The following is a description of a gene set: PURPOSE: To improve the clinical management of human hepatocellular carcinoma (HCC) by accurate identification, at diagnosis, of patients at risk of recurrence after primary treatment for HCC. EXPERIMENTAL DESIGN: Two clinicopathologic variables available at diagnosis, vascular invasion and cirrhosis, together with molecular profiling using Affymetrix human HG-U133A and HG-U133B oligonucleotide probe arrays, were used to identify recurrent HCC disease. RESULTS: HCC patients presented clinically at diagnosis with vascular invasion and cirrhosis showed a high rate (78-83%) of developing recurrent disease within 6 to 35 months. In comparison, most of the HCC patients (80-100%) without vascular invasion and cirrhosis remained disease-free. However, the risk of recurrent disease for HCC patients with either vascular invasion or cirrhosis could not be accurately ascertained. Using a pool of 23 HCC patients with either vascular invasion or cirrhosis as training set, a 57-gene signature was derived and could predict recurrent disease at diagnosis, with 84% (sensitivity 86%, specificity 82%) accuracy, for a totally independent test set of 25 HCC patients with either vascular invasion or cirrhosis. On further analysis, the disease-free rate was significantly different between patients that were predicted to recur or not to recur in the test group (P = 0.002). CONCLUSION: We have presented data to show that by incorporating the status of vascular invasion and cirrhosis available at diagnosis for patients with HCC after partial curative hepatectomy and a novel 57-member gene signature, we could accurately stratify HCC patients with different risks of recurrence. Genes down-regulated in samples from patients with recurrent hepatocellular carcinoma (HCC). from publication Wang SM, Ooi LL, Hui KM (PMID 17975138) Human Gene Set: WANG_RECURRENT_LIVER_CANCER_DN species: Homo sapiens, and this is the list of marker genes: ID2, ETS2, ELL2, SLC27A2, CDC42SE1, PTP4A1, NUDT9, SPACA3, CNGA1 (NCBI Gene Id 1259), INSIG1, TIGD2, MAFB, SAR1B, GCH1, PGGT1B, CDO1